The following is a description of a gene set: from publication MacLachlan TK, Somasundaram K, Sgagias M, Shifman Y, Muschel RJ, Cowan KH, El-Deiry WS (PMID 10644742) species: Homo sapiens Human Gene Set: MACLACHLAN_BRCA1_TARGETS_UP The breast and ovarian cancer susceptibility gene product BRCA1 has been reported to be expressed in a cell cycle-dependent manner; possess transcriptional activity; associate with several proteins, including the p53 tumor suppressor; and play an integral role in certain types of DNA repair. We show here that ectopic expression of BRCA1 using an adenovirus vector (Ad-BRCA1) leads to dephosphorylation of the retinoblastoma protein accompanied by a decrease in cyclin-dependent kinase activity. Flow cytometric analysis on Ad-BRCA1-infected cells revealed a G(1) or G(2) phase accumulation. High density cDNA array screening of colon, lung, and breast cancer cells identified several genes affected by BRCA1 expression in a p53-independent manner, including DNA damage response genes and genes involved in cell cycle control. Notable changes included induction of the GADD45 and GADD153 genes and a reduction in cyclin B1 expression. Therefore, BRCA1 has the potential to modulate the expression of genes and function of proteins involved in cell cycle control and DNA damage response pathways. Genes up-regulated in SW480 cells (colon cancer with mutated p53) upon expression of BRCA1 off an adenovirus vector., and this is the list of marker genes: CDKN1A, PCNA (proliferating cell nuclear antigen), TOP1, TIMP2, KRT2, RHOA, ARHGDIA, TIMP1, CDK16, GAPDH, IGFBP4, GADD45A, CDK4, CDC34, COX7A2L, TOP2A, IGFBP2, DDIT3, MET, LFNG, RAC1